Given this list of marker genes MTNR1B, AVPR1A, AVP, HCRT, GLRA1, here is a description of the gene set: Any process that stops, prevents, or reduces the frequency, rate or extent of transmission of a nerve impulse, the sequential electrochemical polarization and depolarization that travels across the membrane of a neuron in response to stimulation. studied in species Homo sapiens Human Gene Set: GOBP_NEGATIVE_REGULATION_OF_TRANSMISSION_OF_NERVE_IMPULSE